Given this list of marker genes NRG1, SYT17, RABEP1, PPP3R1, NUMB, RNF220, ARC, DRD4, OPHN1, CBLB, ATAD1, USP46, SUSD4, HPCA, USP6, SCRIB, HIP1, TAMALIN, NCDN, VAC14, RALA, LPAR1, ITGB3, EFNB2, MDM2, GSG1L, here is a description of the gene set: species: Homo sapiens Any process that modulates the frequency, rate or extent of endocytosis of neurotransmitter receptor at the postsynapse. Human Gene Set: GOBP_REGULATION_OF_POSTSYNAPTIC_NEUROTRANSMITTER_RECEPTOR_INTERNALIZATION